Given this list of marker genes Timp1, Mmp13, Mmp17, Mmp19, Mmp27, Timp2 (tissue inhibitor of metalloproteinase 2), Mmp23, Mmp28, Mmp3, Mmp16, Mmp2, Mmp21, Mmp11, Mmp9, Tcf20, Mmp14, Mmp24 (NCBI Gene Id 99226), Mmp20, Timp3, Mmp8, Mmp10, Mmp25, Mmp15, Mmp12, Bsg, Mmp1a, Mmp7, Tnf, Timp4, here is a description of the gene set: Matrix metalloproteinases Mouse Gene Set: WP_MATRIX_METALLOPROTEINASES studied in species Mus musculus